Given this list of marker genes EFNB1, FANCM, WNK1, NOTCH2, FGFR2, GNAO1, ARID1B, FANCI, BRCA2, TLL1, NOG, SMO, ARSL, NIPBL, TBX5, CANT1, SCN1B, NR4A2, NXN (NCBI Gene Id 64359), GLI3, SLCO2A1, RETREG1, COL6A2, SLC25A22, FANCA, IHH, PIGP, RHBDF2, BMPR1A, WLS, FIG4, KIF1A, SMARCA4, IFT122, NEK1, PIGF, ACVR1, TRIM8, FANCD2, UBE2A, HS2ST1, CASK, FLI1, DACT1, SUMF1, PTHLH, CTCF, BMPR1B, GATA4, BMP2, BRIP1, RAD51, GRM7, RAD51C, FANCG, KIAA0753, TBR1, CREBBP, FANCE, GRIN1, PNKP, SIK1, HNRNPH1, TBC1D24, VAC14, WNT7A, KCNJ8, C2CD3, SLC32A1, SMARCA2, ZMPSTE24, NEUROD2, KCNN3, TRPV4, MAP3K20, COL6A1, FGFR1, PIGQ, ERF, TWIST1, FGFR3, COL6A3, HYLS1, RFWD3, WDR19, SATB2, FANCC, ARX, SCN2A, HOXD13, ROR2, RAB23, LMNA, EP300, ACTB (actin beta), HPGD, PTEN, ATP6V1B2, SALL1, UBE2T, RIPK4, PIGL, SLX4, EOGT, FANCF, SALL4, BRCA1, KIF7, FANCB, KCNA1, CDKL5, FANCL, GPC4, PALB2, MAD2L2, COL3A1, SOX9, BHLHA9, TP63 (tumor protein p63), ABCC9, DMXL2, KCNH1, GDF5, ERCC4, SCN9A, MED25, COL12A1, XRCC2, here is a description of the gene set: Human Gene Set: HP_ABNORMAL_TOE_PHALANX_MORPHOLOGY species: Homo sapiens Abnormal toe phalanx morphology